Given this list of marker genes NSD2, ZNF699, PUF60, KMT2D, CENPF, KDM6A, here is a description of the gene set: Bilateral renal hypoplasia Human Gene Set: HP_BILATERAL_RENAL_HYPOPLASIA Two sided hypoplasia of the kidney. studied in species Homo sapiens